Given this list of marker genes DHODH, GUSB, VAPA, CCNC, SPRED1, RPP40, RNF26, FEM1B, CHD1L, TSPAN4, SREK1IP1, RHOU, FANCG, ATF6, IZUMO1R, TMEM33, HSPA8, STT3A, TLCD2 (TLC domain containing 2), AURKAIP1, HSPH1 (NCBI Gene Id 9835), RPP14, TBL2, NDUFB2, ATPAF2, CPNE3, MASTL, EXOC8, ANAPC1, LSS, TMEM39A, MRM2, CRCP, DNAJB11, HDLBP (high density lipoprotein binding protein), KIFAP3, COX6B1, ZC3H12C, VPS36, SLC39A6, ACO1, GPRC6A, MFSD10, RTCA, NELFB, C11orf24, BMPR1A, EIF2D, ELP1, TXNDC5, AATF, CCDC115, CDC26, CALU, RAI14, NCF1, PTPN1, CSTB, SSBP1, NCBP2, ALAD, UTP25, HIVEP3, GTF2H1, KIFC1, POLR3G, SRP54, EIF3I, RXYLT1, H2AX, GRN, TRAPPC4, PSPH, RBM28, CLASP1, TNIP2, SARNP, EMC7, INTS3, GSTM3, NDUFS4, GATAD2A, TMEM216, COX6A1, NDFIP1, BNIP1, CCNH, PTPN9, NMNAT1, IMPA1, UQCRC2, TOMM40L, TPRKB, TBC1D24, R3HCC1, SURF4, GPR65, RPL24, OXCT1, ZMYND19, NSUN2, SAC3D1, DMAC1, PYCR3, MPI (mannose phosphate isomerase), ADRM1, LTV1, BMS1, PWP2, UQCRC1, COA6, MLLT11, IL1A, FBL, IDH3B, DOLK, CLPB, GLOD4, CDKN2C, MFSD4B (major facilitator superfamily domain containing 4B), SLC35A4, ITGB1BP1, KPNA6, RNFT1, CDH10, MXD3 (NCBI Gene Id 83463), ELAVL1, GTF2A1, NCBP3, C2CD2L, BDH1, PGRMC2, PRNP, PLCG2, GALNT3, FBXW8, SH3RF1, SEPTIN7, PSMC4, EXOSC5, GLRX3, ANXA3, NDUFS3, GNB1L, TTC8, FKBP4, UNG, WDR4, BLMH, RPL7A, ZBTB14, SPOUT1, OARD1, MLLT1, C1D, SEPTIN2, EIF3A, POLR2H, LRWD1 (NCBI Gene Id 222229), SMN1, ARCN1, UBE2K, PTP4A3, THAP12, COX8A, EFCAB2, PRPS1, RNPEP, U2AF1, WFS1, NASP, SLC52A2, UPP1, NDUFA11, CYB5R1, ZNHIT2, C15orf40, CYP11A1, GNL2, RBM19 (RNA binding motif protein 19), FZR1, COX19, ACLY, POLRMT, ALDH9A1, LRRC40, ATP5F1A, SNRPG, NAA15, MRPS23, WIZ, SAMM50 (NCBI Gene Id 25813), SLC39A8, CCND3, KCNN4, CD320, NXN, TOE1, LANCL2, ZYX, here is a description of the gene set: The aim of this study was to employ a systems-level analysis to elucidate gene expression networks operating in the CD4 T-cell responses which underpin human atopic disease. species: Homo sapiens from publication Bosco A, McKenna KL, Firth MJ, Sly PD, Holt PG (PMID 19414752) Human Gene Set: GSE14908_ATOPIC_VS_NONATOPIC_PATIENT_RESTING_CD4_TCELL_DN Genes down-regulated in resting CD4 T cells: atopy versus healthy.